The following is a description of a gene set: Paracentral scotoma studied in species Homo sapiens Human Gene Set: HP_PARACENTRAL_SCOTOMA, and this is the list of marker genes: ACO2, CFI, CFH, RLBP1, EFEMP1, CYP4V2, HKDC1